Given this list of marker genes CEP135, TGFBR1, ENPP1, NAGPA, ADD2, SORCS1, TARDBP, RBFOX2, CA2, BCL2, CUEDC1, EAF1, MYRF, PHLDB2, SLC38A4, SCLT1, CDK14, ECHDC1, CREB1, KGD4, TTC13, NFATC3, CNOT2, PLEKHA1, RFK, PCGF2, OR2C3, ATL2, DNAJB14, GOLIM4, SINHCAF, ZFHX4, SCAI, ZNRF2, MARCHF6, MYO1B, AAK1, MSRB3, SPAG9, PDZD8, PAN3, C17orf75, ASAP1, TRDN, LPAR1, ZNF12, BCL6B, FMR1, ATRN, TGFBR2, CDC123, GID8, GOLGA6D, TSPAN12, NAA15, CCDC39, DNAH5, ZNF578, CWF19L2, PALMD, ROCK1, NTNG1, AMPD3, OGT, HOXB2, OXNAD1, HSF2, CD28, ACOX3, ZFP30, TENT5A, ALKBH8, MIB1, NR2F2, MLLT1, RNF11, KMT2A, AHCYL1, ESYT3, FBXO8, RASSF9, SOX6, ERBIN, TDRD10, HES5, ACSL1, MMP20, CYP2U1, USF3, TCF12, VANGL2 (VANGL planar cell polarity protein 2), TAF5L, RBM18, PPM1L, C5orf22, PABIR3, NIPAL1, KRAS, BICD2, CCL16, SALL2, RBM41, CSAD, LBR, SLITRK4, SCLY, GPATCH2L, NUDCD2, PIGN, FGFR2, NDFIP2, LRRC46, TBC1D26, RNF2, here is a description of the gene set: Genes predicted to be targets of miRBase v22 microRNA hsa-miR-202-5p in miRDB v6.0 with MirTarget v4 prediction scores > 80 (high confidence targets). studied in species Homo sapiens Human Gene Set: MIR202_5P from publication Chen Y, Wang X (PMID 31504780)